The following is a description of a gene set: Human Gene Set: HP_CLUBBING_OF_TOES Clubbing of toes Terminal broadening of the toes (distal phalanges of the toes). species: Homo sapiens, and this is the list of marker genes: RAD51C, RHBDF2, FANCC, FANCA, SLX4, FANCB, XRCC2 (X-ray repair cross complementing 2), RAD51, SLCO2A1, TLL1, BRCA1, ERCC4, HPGD, FANCE, PIGL, FANCF (NCBI Gene Id 2188), UBE2A, RFWD3 (ring finger and WD repeat domain 3), HNRNPH1, BRCA2, FANCD2, FANCG, PALB2, FANCL, FANCM, SMARCA2, FANCI, BRIP1, MAD2L2, UBE2T